Given this list of marker genes PABIR1, PPP1R14A, PPP4R1, PPP1R15A (NCBI Gene Id 23645), PPP1R37, TIPRL, RCAN3, ELFN1, CALM2, PPP2R5A, SIRPA, PPP1R36, PPP2R5C, CABIN1, CNEP1R1, PPP1R26, CALM1, PPP6R2, PPP1R2, TPRN, SHOC2, PPP1R17, CALM3, PPP1R2C, GNA12, PPP1R15B, ELFN2, PHACTR1, PPP1R14D, PPP4R2, EIF2AK2, PPP1R12B, PPP1R14C, AMBRA1, SBF2, TESC, PPP1R12C, YWHAB, PPP1R35, IGBP1, PPP2R2B, MYOZ1, SH3RF2, PPP1R16A, DMPK, LGALS3, PPP4R4, FRS2, PPP4R3C, RCAN2 (regulator of calcineurin 2), PPP1R9B, HSP90AB1, PPP1R8 (NCBI Gene Id 5511), PPP1R3B, PPP6R3, PPP2R2A, PABIR3, YWHAE, PPP2R5B, ARPP19, PPP2R3A, CD33, GTF2F1, CIP2A, STYX (NCBI Gene Id 730432), PPP1R11, PHACTR2, RCAN1, MGAT5, B3GAT3, PPP2R5E, VRK3, PPP1R1A, PPP1R1C, PPP2R5D, PPP2R2D, CDCA2, PPP1R16B, LMTK2, SET, PHACTR4, BMP2K, PLEK, PPP3R1, PPP2R1B, PPP2R2C, PHACTR3, ENSA, IGFBP3, CRY2, PPP1R1B, PPP1R27, PPP2R1A, IGFBP2, STYXL1, PTN, PPP4R3A, CTNND1 (catenin delta 1), PPP1R2B, PPME1, PTPA, ITGA1, PPP1R2P1, ANKLE2, PPP1R10, PABIR2 (NCBI Gene Id 159090), BMP2, PPP1R14B, VCAN, ANP32E, SLC39A10, PPP4R3B, ZEB2, PPP1R7, PPP2R3B, SAG, URI1, BOD1, HSP90B1, PPP1R12A, PPP3R2, PPP6R1, here is a description of the gene set: Human Gene Set: GOMF_PHOSPHATASE_REGULATOR_ACTIVITY species: Homo sapiens Binds to and modulates the activity of a phosphatase, an enzyme which catalyzes of the removal of a phosphate group from a substrate molecule.